The following is a description of a gene set: Reactome Pathway: RNA Polymerase III Transcription Initiation From Type 1 Promoter species: Homo sapiens part of: RNA Polymerase III Transcription Initiation The type 1 promoters recruit TFIIIA, the founding member of the C2H2 zinc finger family of DNA-binding proteins. The binding of TFIIIA then allows the binding of TFIIC, a complex consisting of five subunits (which differs from the six subunits in S. cerevisiae) in human cells and S. pombe. Once the DNA/TFIIIA/TFIIIC complex is formed, Brf1-TFIIIB joins the complex and this in turn allows the recruitment of RNA polymerase III., and this is the list of marker genes: POLR3E, POLR3B, GTF3C6, POLR3F, TBP, GTF3C3, POLR3C, BRF1, POLR3G, POLR2F (NCBI Gene Id 5435), POLR3A, POLR2L, POLR2K, POLR3K, GTF3C2, POLR3GL, GTF3A, BDP1, CRCP, POLR3D, POLR2H, GTF3C4, POLR3H, GTF3C5, POLR1C, GTF3C1, POLR2E, POLR1D